The following is a description of a gene set: The appearance of type I interferon due to biosynthesis or secretion following a cellular stimulus, resulting in an increase in its intracellular or extracellular levels. Type I interferons include the interferon-alpha, beta, delta, episilon, zeta, kappa, tau, and omega gene families. Mouse Gene Set: GOBP_TYPE_I_INTERFERON_PRODUCTION species: Mus musculus, and this is the list of marker genes: Gbp4, Pycard, Ikbke, Riok3, Mmp12, Irak1, Nmi, Rel, Atg9a, Xiap, Dhx36, Oas1e, Gbp7, Morc3, Tlr3, Ap3b1, Xaf1, Zbtb20, D1Pas1, Hmgb1, Polr3g, Traf3, Tomm70a, Trim27, Ticam2 (TIR domain containing adaptor molecule 2), Oas1b, Dhx33, Polr3b, Atg5, Ticam1, Irf1, Oas1c, Nlrc3, Rnf216 (NCBI Gene Id 97262), Usp22, Cd14, Nlrx1, Cgas, Tlr8, Sirpa, Trim65, Yy1, Gapdhrt, Crebbp, Mavs, Relb, Tlr7, Stat1, Polr3f, Polr3a, Arrdc4 (arrestin domain containing 4), Pola1, Banf1, Ppme1, Oas1g, Kpna2, Acod1, Gapdh, Syk, Ptpn22, Irgm1, Dhx9, Irf9 (interferon regulatory factor 9), Ddx56, Qki, Ptpn11, Traip, Tbk1, Rbx1-ps, Ppm1b, Rnf135, Tank, Polr3d, Peli3, Oas3, Isg15, Uap1, Rigi, Tlr4 (toll-like receptor 4), Gpatch3, Chuk, Tradd, Igtp (NCBI Gene Id 16145), Ptprs (NCBI Gene Id 19280), Nmbr, G3bp1, Trim38, Ufd1, Ilrun, Oas1h, Tirap, Cactin, Traf3ip1, Irf7, Klhl22, Kpna2rt, Garin5a, Pqbp1, Havcr2, Irgm2, Traf6, Rbx1, Hspd1, Flt3, Cul3, Dhx58, Nploc4, Trim15, Irf3, Sting1, Oas1a, Flot1, Trim56, Hmgb2, Rab2b, Oas2, Ddx3x, Trex1, Ifih1, Tyrobp, Ap3d1, Tlr9, Gapdhrt2, Tlr2, Ifnar1, Myd88, Siglec1, Zcchc3, Rnf26rt, Irf8, Polr3c, Rnf26, Traf3ip3, Clec12a, Oas1f, Kat8, Irf5, Rnf125, Zc3hav1, Plcg2, Oas1d, Setd2, Nmb, Atg12, Gapdh-ps15, Hsp90aa1